The following is a description of a gene set: Any process that modulates the frequency, rate, or extent of the chemical reactions and pathways resulting in the breakdown of carbohydrates. species: Homo sapiens Human Gene Set: GOBP_REGULATION_OF_CARBOHYDRATE_CATABOLIC_PROCESS, and this is the list of marker genes: PPARA, SLC4A4 (NCBI Gene Id 8716), DDIT4, OGT, PHKG2, MLXIPL, GIT1, ARNT, SRC, CBFA2T3, INS, HMGB1 (high mobility group box 1), NUPR1 (NCBI Gene Id 26471), MLST8, TREX1, GPD1, MTCH2, ZBTB7A, PPP1R3B, IGF1, JMJD8 (NCBI Gene Id 64483), SLC4A1, KAT2B, PPP2CA, IER3, TRIM63, PRKACA, PFKFB1, UCHL1, MIR210, EP300, APP, ACTN3, GCK, FBP1, PRKAG3, HDAC4, PSEN1, PRKAA2, SLC2A6, GAPDHS (NCBI Gene Id 26330), FLCN, PPP1CA, PRKAA1, P2RX7 (purinergic receptor P2X 7), ADCY10, TIGAR, ARL2, PPP1R3D, MTOR, TP53, HIF1A, SCARB2, ALDOB, INSR, IFNG, PRKAG1, SIRT6, PRXL2C, ZBTB20, HTR2A, PHKA1, STAT3, EIF6, PRKAG2, NCOR1, RPTOR, GSK3A